The following is a description of a gene set: Wnt signaling species: Mus musculus Mouse Gene Set: WP_WNT_SIGNALING, and this is the list of marker genes: Prkci, Prkcb, Fzd1, Wnt5b, Plau, Fzd3, Ccnd1, Mapk10, Wnt2, Fzd7, Fzd8, Pafah1b1, Csnk1e, Ccnd3, Prkd1, Wnt1, Ccnd2, Ppp2r5e, Fzd5, Fosl1, Prkca, Gsk3b, Fbxw2, Wnt10a, Wnt7a (wingless-type MMTV integration site family, member 7A), Jun (NCBI Gene Id 16476), Wnt10b, Rac1, Wnt11, Rhoa, Fzd9, Wnt5a, Prkcz, Wnt3, Myc, Axin1, Frat1, Fzd10, Ppp2r5c, Fzd6, Apc, Sfrp4, Wnt6, Dvl2 (NCBI Gene Id 13543), Dvl1, Ctnnb1, Wnt7b, Wnt4, Prkce, Prkch, Prkcd, Fzd2, Mapk9, Prkcq, Wnt3a, Wnt16, Dvl3, Prkcg, Wnt2b, Ldlr